Given this list of marker genes PMCHL2, SLC6A2, COMT, CDK5, PMCH, DRD4, SLC6A3, RAB3B (RAB3B, member RAS oncogene family), CNTNAP4, FLOT1, TH, CRH, RASD2, PARK7, PNKD, DRD3, ARRB2, SNCA (NCBI Gene Id 6622), DRD5 (dopamine receptor D5), GDNF, TOR1A, DRD2, PRKN, PINK1, CRHBP, SLC6A4, ADORA2A, CHRNB2, DRD1, here is a description of the gene set: Human Gene Set: GOBP_SYNAPTIC_TRANSMISSION_DOPAMINERGIC The vesicular release of dopamine. from a presynapse, across a chemical synapse, the subsequent activation of dopamine receptors at the postsynapse of a target cell (neuron, muscle, or secretory cell) and the effects of this activation on the postsynaptic membrane potential and ionic composition of the postsynaptic cytosol. This process encompasses both spontaneous and evoked release of neurotransmitter and all parts of synaptic vesicle exocytosis. Evoked transmission starts with the arrival of an action potential at the presynapse. studied in species Homo sapiens